The following is a description of a gene set: The formation of the neural tube from an epithelial cell sheet (the neuroepithelium or neural plate). In primary neurulation, the cells surrounding the neural plate direct the neural plate cells to proliferate, invaginate, and pinch off from the surface to form a hollow epithelial tube. Primary neurulation is the typical mechanism of formation of the anterior neural tube. Mouse Gene Set: GOBP_PRIMARY_NEURAL_TUBE_FORMATION studied in species Mus musculus, and this is the list of marker genes: Zeb2, Lrp6 (NCBI Gene Id 77387), Prkaca, Ovol2, Grhl3, Fuz, Bmp5, Sall4, Hif1a, Traf6, Tfap2a, Twist1, Mks1, Ski, Trim71, Bmp7, Cited2 (Cbp/p300-interacting transactivator, with Glu/Asp-rich carboxy-terminal domain, 2), Rps7, Scrib, Tsc1, Apaf1, Rala, Prickle1, Tgif1, Folr1, Pax2, Bcl10, Enah, Tgfb1, Sema4c, Arid1a, Nckap1, Bmp4, Stil, Sufu, Kdm2a, Lias, Cthrc1, Pfn1, Grhl2, Kat2a, Glmn, Zic5, Nog, Sfrp1, Tead2, Fzd3, Zic2, Rgma, Vasp, Ift172, Specc1l, Ptch1, Rab23, Tulp3, Kdm2b, Kdm6a, Abl1, Cobl, Phactr4, Rock2, Shroom3, Alx1, Plxnb2, Cluap1, Luzp1, Spint1, Arhgap35, Vangl2, Hectd1, Kif20b, Prkacb, Abl2, Spint2, Sec24b, Mthfd1l, Pax3, Setd2, Rarg, Rara, Cdk20, Sdc4, Ptk7, Tmed2, Med12, Opa1, St14, Dvl2, Casp3, Cecr2, Celsr1, Tsc2, Cc2d2a, T, Deaf1, Sall1, Mthfr, Brd2, Wdr83, Wnt5a, Cfl1, Lmo4, Lrp2, Fzd6, Lhx2, Nodal, Smarca1, Dlc1, Tgfb2, Mthfd1, Adm, Sfrp2, Ift122, Bbs4, Ift57, Gatad2a